Given this list of marker genes ITIH5, S1PR3, A2ML1, PDGFRB, CCBE1, ITGA1, LRRC17, TRMT9B, RASL12, DCDC2C (doublecortin domain containing 2C), GEM, COLEC10, NTF3, ASPN, ENSG00000233539, CNTN5, GUCY1A2, LGSN, IL1RAPL1, SEPTIN4-AS1, KIF26B-AS1, BCO1, RNU6-1327P, ADGRA2, SKINT1L, ITGA8, SLITRK6, ADRA1B, NDUFA4L2, RBMS3, NID2, LINC02698 (NCBI Gene Id 105369512), COL6A3, CDH19, CARMN, MYO1B-AS1, TMEM132D, KCNE4, EDNRA, ADAMTS13, COLEC11, GPC6, LUM, RPS12P5, TARID, ADAMTSL1, GNAO1-DT, SEMA5A, RXFP1 (NCBI Gene Id 59350), FERMT2, CSPG4, C1QTNF7, LYPD6B, ADCY5, ADAMTS12, DSEL, LRRC78P, VIPR1, NEURL1B, SLC1A7, RBM46, DENND2B, MFAP4, SVEP1, GPR153, HSPB6, SCARF2, ST6GAL2, NKAIN3, LAMA2, LIFR, FGF1, ANO3, LINC02507, LINC00632, MASP1, RPL17P21, MXRA8, CLMAT3, TWIST2, LRRC7, FAT3, ROBO2, LINC02319, FGFR2, ALLC, ANGPTL6, GPC6-AS1, BGN, GGT5, RAI2, RSPO3, DAAM2, COL25A1, POSTN, LY6S-AS1, MDGA2, FAM13C, MUSK, MSC-AS1, FHOD3, IGFBP3, CCDC3, SLC17A8, RIT2, TRPC3, DIO3OS, LZTS1, B3GAT2, NPAP1, NWD2, AHRR, NGFR, LHX2, PDGFRA, SEPTIN4, SYNPO2, RBMS3-AS3, VSTM4, GRIN2D, ADCYAP1R1, EPHA3, TACR1, STEAP4, DBH, FBXO24, LMO7-AS1, ADGRB3, KIF26B, BMP5, FGF10 (fibroblast growth factor 10), C1QTNF2, CDH4, NR1H4, DACT3, PKNOX2 (NCBI Gene Id 63876), FGF10-AS1, TBX2-AS1, CXCL14, ALPL, BMPR1B, PTH1R, ENSG00000264449, DACH2, LRAT, LAMB1, CCDC178, HS3ST3B1, LINC02237, RPS6KA6, SPRY1, NES, CACNA2D1, ABCC9, AFAP1L2, NBPF3, HGF, INS-IGF2, DIO3, TBX2, here is a description of the gene set: The gene expression program underlying the specification of human cell types is of fundamental interest. The study authors generated human cell atlases of gene expression and chromatin accessibility in fetal tissues. For gene expression, the study authors applied three-level combinatorial indexing to >110 samples representing 15 organs, ultimately profiling ~4 million single cells. The study authors leveraged the literature and other atlases to identify and annotate hundreds of cell types and subtypes, both within and across tissues. Our analyses focused on organ-specific specializations of broadly distributed cell types (such as blood, endothelial, and epithelial), sites of fetal erythropoiesis (which notably included the adrenal gland), and integration with mouse developmental atlases (such as conserved specification of blood cells). These data represent a rich resource for the exploration of in vivo human gene expression in diverse tissues and cell types. from publication Cao J, O'Day DR, Pliner HA, Kingsley PD, Deng M, Daza RM, Zager MA, Aldinger KA, Blecher-Gonen R, Zhang F, Spielmann M, Palis J, Doherty D, Steemers FJ, Glass IA, Trapnell C, Shendure J (PMID 33184181) Human Gene Set: DESCARTES_FETAL_LIVER_STELLATE_CELLS Marker genes curated from the annotated cluster as represented in the Descartes Human Gene Expression During Development database. studied in species Homo sapiens